Given this list of marker genes Ppa1, Icam1, Mndal, Pik3ip1, Anp32b, Ly6a, Psmb10, Cyb5a, Tapbp, Myl12b, Il27ra, Tsc22d3, Phgdh, Ddit4, Tapbpl, Pa2g4, G3bp1, Ifi47, Ldha, Tcf7, Ly6e, Vars1, Eif5a, Stat3, Nfkbia, Ddit3, Ptp4a2, Mapkapk2, Chmp4b, Rtp4, Psme2, Isg15, Zfp36l2, Xaf1, Igfbp4, Ctss, Birc3, Ncl, Mars1, Sumo2, Batf (NCBI Gene Id 54359), Apobec3, Bbc3, Socs1, Relb, Odc1, Lars1, Iars1, Parp14, Ccnd3, Socs3, Psme1, Aars1, Gramd2b, Sdhaf1, Eif2s2 (NCBI Gene Id 99435), Bcl3, Cd82, Nfkb2, Ptma, Il7r, Cyba, Arid5b, Gbp2, Shmt2, Larp1, Serinc3, Mthfd2, Fkbp5, Zbp1, here is a description of the gene set: Genes positively differentially expressed in cell type: CD8+ T cell upon treatment with cytokine: TNF-α in mouse lymph nodes in vivo. Cytokines mediate cell-cell communication in the immune system and represent important therapeutic targets. A myriad of studies have highlighted their central role in immune function, yet we lack a global view of the cellular responses of each immune cell type to each cytokine. To address this gap, the authors created the Immune Dictionary, a compendium of single-cell transcriptomic profiles of more than 17 immune cell types in response to each of 86 cytokines (>1,400 cytokine-cell type combinations) in mouse lymph nodes in vivo. A cytokine-centric view of the dictionary revealed that most cytokines induce highly cell-type-specific responses. For example, the inflammatory cytokine interleukin-1β induces distinct gene programmes in almost every cell type. A cell-type-centric view of the dictionary identified more than 66 cytokine-driven cellular polarization states across immune cell types, including previously uncharacterized states such as an interleukin-18-induced polyfunctional natural killer cell state. species: Mus musculus Mouse Gene Set: CUI_T_CELL_CD8_TNFA_RESPONSE_UP from publication Cui A, Huang T, Li S, Ma A, Pérez JL, Sander C, Keskin DB, Wu CJ, Fraenkel E, Hacohen N (PMID 38057668)